The following is a description of a gene set: studied in species Mus musculus Mouse Gene Set: GOBP_T_HELPER_17_CELL_DIFFERENTIATION The process in which a relatively unspecialized T cell acquires the specialized features of a T-helper 17 (Th17) cell. A Th17 cell is a CD4-positive, alpha-beta T cell with the phenotype RORgamma-t-positive that produces IL-17., and this is the list of marker genes: Zbtb7b, Tgfb1, Rorc, Stat3 (NCBI Gene Id 68733), Rc3h1, Nfkbid, Il4, Ccr6, Lgals1, Tnfsf18, Slamf6, Nlrp3, Cd69, Ep300, Malt1 (MALT1 paracaspase), Il6, Ccl20, Rc3h2 (ring finger and CCCH-type zinc finger domains 2), Smad7, Mir326, Ascl2, Il2, Entpd7, Pf4, Ly9, Opa1, Rora, Nfkbiz, Batf, Brd4, Mir873a, Tbx21, Il6ra, Il23a, Foxp3, Zc3h12a, Irf4, Otud5, Brd2, Loxl3, Mir301